The following is a description of a gene set: The process in which the anatomical structures of blood vessels of the heart are generated and organized. The blood vessel is the vasculature carrying blood. species: Mus musculus Mouse Gene Set: GOBP_CORONARY_VASCULATURE_MORPHOGENESIS, and this is the list of marker genes: Epor, Prok2, Ctnnb1, Fgfr2, Fgf9, Fgf1, Smad6, Sgcd, Angpt1, Sec24b, Spred1, Lrp2, Tbx1, Vegfa, Epo, Hand2 (heart and neural crest derivatives expressed 2), Ace, Rxra, Tgfbr1 (NCBI Gene Id 674605, transforming growth factor, beta receptor I), Setd2, Zfpm2, Shh, Notch1, Arid2, Pdgfrb, Hey2, Fgf2, Tgfbr3, Nrp1, Gata4, Pbrm1, Fgfr1